Given this list of marker genes CCDC28B, RNF26, DOLK, SRRM1, TTC9, MYO1E, ENOX2, BCL9L, CACTIN, UNC5CL, NTHL1 (NCBI Gene Id 4913), RPTOR, NOP2, FAM118A, LETM1, PRPF8, ANKRD30B (NCBI Gene Id 374860), QTRT2, MMAB, AFG2A, RIN1, ZNF331, EPHB6, YDJC (NCBI Gene Id 150223), MEF2D, VAC14, IVD, ADCK5, ZNF675, PHF1, CCDC61, ALKBH4, GLCE, ZBTB40, EIF3B, ARHGEF18, MYEF2, APOD, KIR2DS5, RHOBTB2, METTL25B, NEURL4, LAMP3, RFPL1, POFUT1, YJU2, ZNF571, HNRNPU, RNF126P1, TCOF1, KRI1, XPC, ZNF707, USP36, LYVE1, LMF1, STING1, DYRK1A, SHROOM1, ENO3, STAC3, TMEM129, PPP1R13B, PDCD5, GLO1, SNX8, HHAT, ANKLE1, RPAP1, POLG, CCDC142, DISP1 (dispatched RND transporter family member 1), SURF2, DCAF4, ACER1, ZNF577, SOBP, FAAP24, IDUA, A1BG-AS1 (A1BG antisense RNA 1), DCK, DPP9, GABPB1-IT1 (NCBI Gene Id 55056), SPRYD7, DNAJC30, SGCA, ZNF329, ANXA2P3, IMMP2L, UQCC1, EPB41L4A, NF2, ZNF223, MAP3K6, MYBBP1A, HEXIM2, PINX1, EZR (NCBI Gene Id 7430), DSEL, SGF29, PACS1 (phosphofurin acidic cluster sorting protein 1), FAM53B, OSBPL5, ZNF79, CIC, ZNF543, PGAP3, NSUN4, SLC9A3-AS1, FABP2, TNPO2, TPCN2, NAT9, MANF, PORCN, TMEM150A, MBTPS1, HCFC1, ZMIZ1, IFI27L2, DSPP, C7orf33, ALKBH5, CLCN7, ANXA2P1, TRMU, SLC35C1, SPOP, RIOX1, TPPP3, CCNQ (cyclin Q), PIP4K2B, PRR12, BET1L, LTO1, CAPN15, UAP1L1, AMH, ZNF503, CLPX, WIZ, CA6, ZNF175, EXO5, CHD4, DNAH12, ALG12, GIPC1, ESRRA, LTK, CABIN1, TBCD, ZNF284, DHX58, KLF8, ZNF628, AARSD1, RRP9, RRP7A, PPIL2, UBTF, RCE1, PELP1, TGIF1, FAM174C, DUSP14, FBXL14, ZNF286A, SDHAP2, AZGP1, ZNF786, SLC35E4, SLC16A9 (solute carrier family 16 member 9), TRIM3, DCAF6, TCEA3, ZNF790-AS1, HECTD3, RCN3, OPA3, TMEM14B, TSR1, SNX4, PEG10, TAF1C, PHEX, ZBTB7A, NT5E, GPR162, UCP2, KLHL36, ZNF91, ZNF85, here is a description of the gene set: Murine Cytomegalovirus (MCMV) infection leads to early activation of various immune cells, including B and T lymphocytes, before the actual initiation of antigen-specific adaptive immunity. This activation is partly driven by innate cytokines, including type I interferon (IFN), which are induced early after infection. The objective of this study was to address the role of type I IFN in shaping early/innate B and T cell responses to a primary acute viral infection. In order to decipher the specific impact of IFN-I on cell subsets, we performed a genome-wide expression analysis on WT splenic B and CD8 T lymphocytes isolated from C57BL/6 mixed bone marrow chimera mice. This study complements series GSE39555, which focused on early responses of NK cells and of the two subsets of conventional dendritic cells. Human Gene Set: GSE45365_WT_VS_IFNAR_KO_CD11B_DC_MCMV_INFECTION_UP Genes up-regulated during primary acute viral infection in ITGAM+ dendritic cells: wildtype versus IFNAR1 knockout. studied in species Homo sapiens